Given this list of marker genes NADK, NUDT8 (nudix hydrolase 8), PARP16, SLC52A2, SLC5A6, AASDHPPT, NMRK1, PANK2, CD320, QPRT, NAPRT, SLC25A51, MTHFD1L, MOCS1, NT5E, NMRK2, PANK4, GSTO1, PARP8, NMNAT1, PARP9, PARP14, ENPP1, ABCC1, SLC19A3, MTHFS, NNMT, THTPA, MMUT, ALDH1L2, MMAB, VNN2, PARP6, ACACA, HLCS, PANK1, AOX1, NAXD, CD38, MOCOS, SLC25A16, SLC5A8, NADK2 (NAD kinase 2, mitochondrial), SLC19A2, FLAD1, TCN2, RFK, CBLIF, PCCA, MTHFD1, CUBN, LDLRAP1, SLC25A42, CTRB2, TCN1, NUDT12, NFS1, PC, SLC52A3, TPK1, CYB5R3, CTRB1, GPHN, LMBRD1, SLC25A32, ACACB, MTHFD2, MTRR, NMNAT2, PARP10, MMAA, FOLR2, MMADHC (metabolism of cobalamin associated D), PDZD11, MCCC1, MCCC2, DHFR, ENPP2, FASN, SLC2A1, COASY, SLC23A2, MOCS3, NADSYN1, CYB5A, ACP5, PARP4, SLC23A1, PCCB, ALDH1L1, PNPO, NMNAT3, PRSS3, DHFR2, GSTO2, PANK3, ABCD4, BST1, SLC25A19, RNLS, MTR, NAMPT, SLC2A3, LRP2, SHMT2, PPCDC, PDXK, SLC52A1, MTHFR, MTHFD2L, SLC19A1, PRSS1, SHMT1, NAXE, BTD, MOCS2, FPGS, AMN, DCAKD, SLC22A13, SLC46A1 (solute carrier family 46 member 1), PPCS, ENPP3, VNN1, MMACHC, here is a description of the gene set: Metabolism of water-soluble vitamins and cofactors studied in species Homo sapiens Human Gene Set: REACTOME_METABOLISM_OF_WATER_SOLUBLE_VITAMINS_AND_COFACTORS